Given this list of marker genes Prxl2b, Fabp5 (NCBI Gene Id 16592), Cd74, Pla2g4f, Tbxas1, Sco1, Mif, Daglb, Avpr1a, Il1b, Ptges3-ps, Cthrc1, Pla2g2a, Anxa1, Ptgds, Ptges2, Pla2g4a, Sirt1, Pla2g10, Ptges, Pla2g3, Pibf1, Sphk1, Ptges3, Edn1, Mapk9, Ptgs2, Pnpla8, Hpgds, Edn2 (NCBI Gene Id 13615), Avp, Ptgis (NCBI Gene Id 19223), Ptgs1, here is a description of the gene set: species: Mus musculus Mouse Gene Set: GOBP_PROSTANOID_BIOSYNTHETIC_PROCESS The chemical reactions and pathways resulting in the formation of prostanoids, any compound based on or derived from the prostanoate structure.